Given this list of marker genes TUBA1B, PSMC6, PSMD3, WDR35, PSMD11, INTU, CSNK1A1, PSMB4, PRKACA, GNAS, PRKAR1A (protein kinase cAMP-dependent type I regulatory subunit alpha), PSMD8, TUBA3D, FUZ, NUMB, PSMD12, OFD1, CUL1, BTRC, PSMD7, TUBA4A, PSMB2, PSMC4, IFT57, PSMA6, UBC, ADCY8 (adenylate cyclase 8), ADCY10, ADCY9, TUBB4B, WDR19, ADCY2, DYNC2H1, SUFU, IFT172, PSMD13, PRKAR1B, GSK3B, KIF3A, ADCY6, PSMC2, PSMC5, SKP1, SMO, PSMA3, GPR161, PTCH1, RPS27A, ADCY5, TUBB1, TTC21B, IFT122, PSMA2, TUBA1C, PRKACG, ADRM1, IFT88, TUBB4A, PSMC1, PSMB6, ADCY1, MKS1, PSMB1, ADCY7, GLI3, KIF7 (kinesin family member 7), PSMB3, PSMD6, TUBB3, PRKAR2A, ITCH, GLI2, PSMD2 (proteasome 26S subunit ubiquitin receptor, non-ATPase 2), TULP3, PSMA7, PSMC3, TUBB6, RBX1, PSMA4, ADCY4, SEM1, IFT140, PSMA5, ADCY3, PSMB7, UBB, PSMA1, PSMD1, TUBA1A, TUBB2A, TUBA3C, PRKACB, PRKAR2B, PSMD14, RPGRIP1L, PSMB5, TUBB2B, IFT52, UBA52, GLI1, here is a description of the gene set: species: Homo sapiens part of: Signaling by Hedgehog Hedgehog is a secreted morphogen that has evolutionarily conserved roles in body organization by regulating the activity of the Ci/Gli transcription factor family. In Drosophila in the absence of Hh signaling, full-length Ci is partially degraded by the proteasome to generate a truncated repressor form that translocates to the nucleus to represses Hh-responsive genes. Binding of Hh ligand to the Patched (PTC) receptor allows the 7-pass transmembrane protein Smoothened (SMO) to be activated in an unknown manner, disrupting the partial proteolysis of Ci and allowing the full length activator form to accumulate. <br>While many of the core components of Hh signaling are conserved from flies to humans, the pathways do show points of significant divergence. Notably, the human genome encodes three Ci homologues, GLI1, 2 and 3 that each play slightly different roles in regulating Hh responsive genes. GLI3 is the primary repressor of Hh signaling in vertebrates, and is converted to the truncated GLI3R repressor form in the absence of Hh. GLI2 is a potent activator of transcription in the presence of Hh but contributes only minimally to the repression function. While a minor fraction of GLI2 protein is processed into the repressor form in the absence of Hh, the majority is either fully degraded by the proteasome or sequestered in the full-length form in the cytosol by protein-protein interactions. GLI1 lacks the repression domain and appears to be an obligate transcriptional activator.<br> Vertebrate but not fly Hh signaling also depends on the movement of pathway components through the primary cilium. The primary cilium is a non-motile microtubule based structure whose construction and maintenance depends on intraflagellar transport (IFT). Anterograde IFT moves molecules from the ciliary base along the axoneme to the ciliary tip in a manner that requires the microtubule-plus-end directed kinesin KIF3 motor complex and the IFT-B protein complex, while retrograde IFT back to the ciliary base depends on the minus-end directed dynein motor and the IFT-A complex. Genetic screens have identified a number of cilia-related proteins that are required both to maintain Hh in the 'off' state and to transduce the signal when the pathway is activated. Reactome Pathway: Hedgehog 'off' state